Given this list of marker genes VPS52, DCTN4, NCAM1, USP33, NAA25, RABGEF1, LUC7L3, SYNC, NFYA, NEIL2, NAB1, USP9X, SCARB2, VPS26B, REPS1, MARCHF6, ZNF566, ZNF529, BTRC, SPAG9 (NCBI Gene Id 9043), SUFU, HECTD1, MTMR3, TBCK, NLK, NAA30 (N-alpha-acetyltransferase 30, NatC catalytic subunit), USP19, ZFAND5, FBXO30, RBM4B, ISCA1, SS18L1, FOXO3, EXOC5, ELP1, IQCK, CDIPT, KAT6B, ZFP14, MED13, PHF2, KIDINS220, DMTF1 (NCBI Gene Id 9988, cyclin D binding myb like transcription factor 1), PPIG, KMT5B, CRNKL1, CEP170 (centrosomal protein 170), ZNF133, C2CD5 (C2 calcium dependent domain containing 5), BSDC1, PKNOX1, ZNF84, SPAST, UBE2N, UBQLN2, DYNC1I2, ANKRD17, NCOA5, EIF4ENIF1, SLC35E2A, NGRN, AARS2, SMAD5, CHTOP, CELF1, UFSP2, PAGR1, BRPF3, KMT2A, MFAP3, POGZ, CCDC82, FBXO3, RABL2B, TRAPPC6B, RALGAPA1, EPC2, here is a description of the gene set: Neighborhood of SUFU Neighborhood of SUFU suppressor of fused homolog (Drosophila) in the GCM expression compendium Human Gene Set: GCM_SUFU studied in species Homo sapiens